Given this list of marker genes ZNF385A, TFPI2, RGS19 (regulator of G protein signaling 19), CA13 (carbonic anhydrase 13), MARCHF7, ADAM9, ZP2, IDO2, GIPR, SNORD89, FABP1, HOXB7, CEBPD, MYL9, GIP (NCBI Gene Id 2695), SATB1, SMOC2, KRTAP13-2, HOXA11-AS, FFAR2, CCDC71L, ATP4B, HSD3B2, PTPRA, CCDC87, REPIN1, TCTA, CD14, LRP1, ABI3, HERC1, IL12RB2, AFF1 (ALF transcription elongation factor 1), GPR132, C9, L1CAM, CIAO2A, RHOV, SWAP70, RAD52, SESN3 (sestrin 3), GATA5, PGS1, TNFRSF1A, RPL3L, CD28 (CD28 molecule), KLRD1 (NCBI Gene Id 92677), ECM2, KDSR, EBF1, LRP12, ZBTB20, TIMP1, TBCEL, LNPEP, C1QC, RIT1, GNB1L, TSHZ2, TULP3, TRO (NCBI Gene Id 7216), BET1L (Bet1 golgi vesicular membrane trafficking protein like), IFT57, EID3, PNMA8A, ZMAT3, HLA-G, SLC18A1, FAM234B, GEM, GRIK4, DERL1, CRIP2, ACADL, LY6D, PIGK, WBP2, TAX1BP1, MT2A, SORCS3-AS1, DSCAM, CYSLTR2, MOB3A, C19orf12, MASP2, LRP3, CUBN, CDH10, MORN3, TSPAN4, TEKT3, VEGFD, MDFIC (MyoD family inhibitor domain containing), GPR65, AVL9, PAK6, PPP1R13B, MACROH2A1, CSTA, MDM2, IL27RA, TTC39A, CTSD, SLC22A9, RIMS3, BPIFB1 (BPI fold containing family B member 1), GADD45A, THNSL1, TIRAP, SNX20, MUSK, MED13L (NCBI Gene Id 23389), RRM2B, TRPC4AP (transient receptor potential cation channel subfamily C member 4 associated protein), AKAP6, FRMD4B, NPDC1, CCNG1, LRIT1, UCHL1 (ubiquitin C-terminal hydrolase L1), VEPH1, SMURF1, S1PR3, SEMA3B, ETV6, SERPINB1, KLRK1, CHD7, ENTREP2, PGAM1, GNPDA2 (NCBI Gene Id 132789), LINC00612, MAN2B2, TECRL, PRSS8, MYLK2, ZC3H12D, GCNT3, PLAC8, TMEM151B, BMERB1, IGF1, PWWP2B, ALDH1A1, AMZ1 (NCBI Gene Id 155185), PRPH, NYAP1, WNT2, SERPINF1, COX18, ZDHHC18, NCOA1, PACS2, PM20D1, UBA1, GFPT2, IL1R2, LRRC52, S100A4, LIF, ACLY, PCDHAC1, CDC34, KMT2D, TBC1D12, CLEC12B, LAPTM5 (lysosomal protein transmembrane 5), CNTN3, TMEM30A, EIF5A2, MMRN2, MAGEB4, WDFY4, TSPY1, ZC3H12A (zinc finger CCCH-type containing 12A), AGO4, SPDYA, LAMP2, IGFBP3, FN3K, MFSD2A, FTCD, FAM177A1, PARP3, SMAD3, ADGRB2, TBC1D20, STAC2, CD80, ACBD5, MARCHF10, MFNG, STK25 (serine/threonine kinase 25), OXNAD1, MCTP2, ZNF750, FOSL2, CADM4 (NCBI Gene Id 199731), ZMYND11, here is a description of the gene set: studied in species Homo sapiens Genes up-regulated in IL10 knockout macrophages: unstimulated versus LPS. from publication Yang HT, Wang Y, Zhao X, Demissie E, Papoutsopoulou S, Mambole A, O'Garra A, Tomczak MF, Erdman SE, Fox JG, Ley SC, Horwitz BH (PMID 21217011) Human Gene Set: GSE19941_UNSTIM_VS_LPS_STIM_IL10_KO_MACROPHAGE_UP Bone marrow-derived macrophages were produced from mice lacking IL-10 alone (IL10-def) or mice lacking both IL-10 and the p50/p105 subunit of NF-kB (p50/IL10), and left unstimulated, stimulated with LPS (1 ng/ml) or stimulated with LPS and IL-10 (0.3 ng/ml).